The following is a description of a gene set: species: Mus musculus The chemical reactions and pathways involving platelet activating factor, 1-O-alkyl-2-acetyl-sn-glycerol 3-phosphocholine, where alkyl = hexadecyl or octadecyl. Platelet activating factor is an inflammatory mediator released from a variety of cells in response to various stimuli. Mouse Gene Set: GOBP_PLATELET_ACTIVATING_FACTOR_METABOLIC_PROCESS, and this is the list of marker genes: Lpcat2, Pla2g5, Pla2g7, Pla2g6 (NCBI Gene Id 53357), Pla2g10, Pla2g4a, Pla2g4c, Chpt1